The following is a description of a gene set: Down-regulated genes in medulloblastoma tumors from heterozygotic CXCR6 knockout mice compared to those from PTCH1 heterozygotic knockout mice. from publication Sasai K, Romer JT, Kimura H, Eberhart DE, Rice DS, Curran T (PMID 17413002) studied in species Mus musculus The sonic hedgehog (Shh) pathway is activated in approximately 30% of human medulloblastoma resulting in increased expression of downstream target genes. In about half of these cases, this has been shown to be a consequence of mutations in regulatory genes within the pathway, including Ptc1, Smo, and Sufu. However, for some tumors, no mutations have been detected in known pathway genes. This suggests that either mutations in other genes promote tumorigenesis or that epigenetic alterations increase pathway activity in these tumors. Here, we report that 3% to 4% of mice lacking either one or both functional copies of Cxcr6 develop medulloblastoma. Although CXCR6 is not known to be involved in Shh signaling, tumors derived from Cxcr6 mutant mice expressed Shh pathway target genes including Gli1, Gli2, Ptc2, and Sfrp1, indicating elevated pathway activity. Interestingly, the level of Ptc1 expression was decreased in tumor cells although two normal copies of Ptc1 were retained. This implies that reduced CXCR6 function leads to suppression of Ptc1 thereby increasing Smoothened function and promoting tumorigenesis. We used a direct transplant model to test the sensitivity of medulloblastoma arising in Cxcr6 mutant mice to a small-molecule inhibitor of Smoothened (HhAntag). We found that transplanted tumors were dramatically inhibited in mice treated for only 4 days with HhAntag. These findings suggest that HhAntag may be effective against tumors lacking mutations in known Shh pathway genes. Mouse Gene Set: SASAI_TARGETS_OF_CXCR6_AND_PTCH1_DN, and this is the list of marker genes: Adam28, Pip5k1a, Apod, Mdk, Prm1, Tfpi, Otx1, Dazl